Given this list of marker genes Adm, Pdpk1, Gnb3, Gng4, Gnb2, Nfkbia, Prkar2b, Gngt1, Gnb5, Itga5, Gngt2, Gng11, Rela, Nfkb1, Calm1, Ppp2r1b (protein phosphatase 2, regulatory subunit A, beta), Anxa2, Gng7, Ptk2, Rictor, Gng10, Prkacb, P2ry2, Gng5, Gng3, Prkar1b, Prkaca, Ppp2r2a, Yap1, Gng8, Ikbkb, Capns2, Ptpn1, here is a description of the gene set: electronically inferred by orthology from the curated human pathway This event has been computationally inferred from an event that has been demonstrated in another species.<p>The inference is based on the homology mapping from PANTHER. Briefly, reactions for which all involved PhysicalEntities (in input, output and catalyst) have a mapped orthologue/paralogue (for complexes at least 75% of components must have a mapping) are inferred to the other species. studied in species Mus musculus part of: Cellular responses to stimuli Reactome Pathway: Cellular responses to mechanical stimuli